Given this list of marker genes PYHIN1, CD9, CAMP, MAGED1, MMP9, XDH, CXCR6, CP, TENT5C, CHIA, F2RL1, B3GALNT1, TFEC, RASGRP3, BASP1, ZBTB20, S100A8, SERPINA3, CACNA1H, SELENOM, PLSCR1, ITK, GIMAP8, GIMAP4, SMR3A, KLRC1, CD3D, EIF2S3, NBEA, CHST1, PLAAT3, SLFN12, CTSG, AFP, ELL2, ITGAL, LTF, LCN2, IGHV4-31, PRG2, HLA-B, PRLR, F2R, SLC25A24, AMY2B (amylase alpha 2B, NCBI Gene Id 280), HBA2, VAV3 (vav guanine nucleotide exchange factor 3), OSBPL3, CACNA1S, RNASE3, LPAR4, FADS3, CRYBA4, ABI3BP, GPM6A, GPR160, ARMCX2, IGHA2, OOSP1, ZBP1, NKG7, SPON1, TNFRSF17, PRTN3, ITGA1 (integrin subunit alpha 1), EPCAM (NCBI Gene Id 4275), MPO, ISG20, CD177, FGL2, ELANE, CCL5, CSTA, ARMCX3, MFSD4A, PGLYRP1, CTSW, RMDN2, FYB1, CPE, IGSF6, IL2RB, LYZ, GBP6, IL18R1, LRG1, DDX3Y, SPAG6, GRAMD1C, LTB, APP, SCART1, HP, JCHAIN, IGKV4-1 (NCBI Gene Id 28908), CPEB3, TMEM176A, PAWR, FSCN1, IFI16, ATAT1, IFITM3, S100A9, CCR2, IGKV2D-29, RECK, TRBC2, ZBTB16, LTB4R, IGKV1-27, FPR1, PLIN3, TRGC1 (NCBI Gene Id 6966), TGFBI, WIPI1, TRDC, C3, C6orf136, ALCAM, HOOK1, STAT4, HDC, IGKV1-16, IGHG1, ARHGAP6, here is a description of the gene set: studied in species Mus musculus from publication Boylan KL, Gosse MA, Staggs SE, Janz S, Grindle S, Kansas GS, Van Ness BG (PMID 17483317) Human Gene Set: BOYLAN_MULTIPLE_MYELOMA_PCA1_UP Top up-regulated genes from principal component 1 (PCA1) which captures variation between normal plasma cells and tumors arising from aberrant expression of BCL2L1 and MYC. Multiple myeloma is an incurable plasma cell malignancy for which existing animal models are limited. We have previously shown that the targeted expression of the transgenes c-Myc and Bcl-X(L) in murine plasma cells produces malignancy that displays features of human myeloma, such as localization of tumor cells to the bone marrow and lytic bone lesions. We have isolated and characterized in vitro cultures and adoptive transfers of tumors from Bcl-xl/Myc transgenic mice. Tumors have a plasmablastic morphology and variable expression of CD138, CD45, CD38, and CD19. Spectral karyotyping analysis of metaphase chromosomes from primary tumor cell cultures shows that the Bcl-xl/Myc tumors contain a variety of chromosomal abnormalities, including trisomies, translocations, and deletions. The most frequently aberrant chromosomes are 12 and 16. Three sites for recurring translocations were also identified on chromosomes 4D, 12F, and 16C. Gene expression profiling was used to identify differences in gene expression between tumor cells and normal plasma cells (NPC) and to cluster the tumors into two groups (tumor groups C and D), with distinct gene expression profiles. Four hundred and ninety-five genes were significantly different between both tumor groups and NPCs, whereas genes were uniquely different from NPCs in tumor group C and genes were uniquely different from NPCs in tumor group D. Similar to human myeloma, the cyclin D genes are differentially dysregulated in the mouse tumor groups. These data suggest the Bcl-xl/Myc tumors are similar to a subset of plasmablastic human myelomas and provide insight into the specific genes and pathways underlying the human disease.